The following is a description of a gene set: studied in species Mus musculus Mouse Gene Set: MIR_361_3P from publication Chen Y, Wang X (PMID 31504780) Genes predicted to be targets of miRBase v22 microRNA mmu_miR_361_3p in miRDB v6.0 with MirTarget v4 prediction scores > 80 (high confidence targets)., and this is the list of marker genes: Ebf1, Scaf11, Tnk2, Ctdsp1, Tgfbr3, Stc2, Camk2b, Adra2c, Mtmr1, Psmd2, Spry4, Klrg1, Dagla, Ogt, Prrt2, Hoxa10, Gpr85, Bcl2l13, Tfe3, Mgl2, Fbxl19, Tfcp2l1, Irgq, Map3k5, Lrcol1, Szrd1, Tns1, Cdk5r2, Kdm5c, Cpeb1, Qsox2, Cacna2d2, St6galnac6, Hpca, Hbp1, Vipr1, Adcy9, Ank2, Serpinb3a, Prkcq (protein kinase C, theta), Zfp410, Ankrd45, Gabbr2, Mark2, 2610008E11Rik, Nfat5, Ap3s2, Rarg, Umodl1 (NCBI Gene Id 52020), Scamp1, Cyp2g1, Zfp772, Tmem127, Fbxw8, Gla, Ajuba (ajuba LIM protein), Pcx, Sfrp5, Rbbp9, Ddo, Slc1a2, Pde1c, Dpf3, Cbx6, Phactr2, Hoxc8, Arhgef9, Serpinb3b, Stau2